Given this list of marker genes FANCC, HTR3C, SUFU, OPRM1 (NCBI Gene Id 4988), ZNF70, CAPZB, NDST1, SMARCD1, TFDP1, PEF1 (penta-EF-hand domain containing 1), TIFAB, STRN4, SDC3, RNF24, NGEF, HGH1, AUTS2, SLC4A5, ESAM, IKZF1, VEGFA, POLR2F, SHISA7, TSLP, MAPKBP1, SEMA5A, KIAA1671, DIXDC1, KCNB1, XPNPEP3, KDM4E, PLXNA1, IL1R1, MYRF, SCAMP5, CDPF1, KCTD7 (potassium channel tetramerization domain containing 7), MITF, NRXN2, RGMA, CNTN2 (NCBI Gene Id 6900), TTC28, TAP2, EEF1AKMT3, PRICKLE1, LINC03040, MRPL19, RAB30 (RAB30, member RAS oncogene family), IFFO2, SELENON, SPOCK2, LBH, COL11A2, PRX, SLC6A6, CERS2, ARHGEF11, EXOC3L2, BCORL1, TTC39C (NCBI Gene Id 125488), TMCC2, CD82, IL17RD, CLDN19, ZDHHC3, FOXM1, MAP2K3, SZRD1, FAM107A, SV2C, ZFR2 (NCBI Gene Id 388494), MEF2D, C5orf24, KCNC4, FAM222B, FADS2, AGO1, BEND4, RBFOX2, RCC2, MARCHF6, RNF121, RAP1GAP2, CRYM (crystallin mu), SLC7A6, NXF1, DHRS2, MEF2A, GLRA4, NCCRP1, SPRR2D, TBC1D20, IDO2, DCC, GRAMD2A, HMGA2, GXYLT1, CREBL2, ZNF747, APBA2, OSBP, CLN8, SLC20A2, FCHSD1, GIPC1, ARHGDIA, HTR4, MTCL2, ZNF185, MAP1A, KIAA0513, COL8A2, BRAP, SH3BGRL3, PAPOLB, INSM2, LRRC27, B3GNT7, MTUS2, FBXO41, CDK2AP2, C19orf84, KRTAP5-2, SPRR2A, KBTBD12, EIF4EBP2, NUTM2G (NUT family member 2G), AIF1L, TRIP6, JRK, FAM20A, PDS5B, DDB1, HAPLN4, CDC42EP4, CDK14, SPRR2E, GLIS3, ABHD2, APPL1, NFAT5, KBTBD13, AEN, NFAM1, ZBTB4, DCAF8, ATP6V0D1, ERCC6L2, LINC02873, EVC, SKI, FLOT2, TOM1L2, ADAM19, G6PC3, FMNL3, RAPGEF1, SPINT3, PRMT5, PIGZ, ADARB1, STN1, SAMD4B, PCYT1A, GPATCH11, NR1D2, PDGFRB, RAB43, SPRR2F, PLXNA2, ARF3, ZNF385A, CDK12, TDO2, CLCN6, MYO18A, DGKH, RAB15, DUSP3, NMUR1, GTF2H3, DIPK2A, GREM1, FOXK1 (forkhead box K1), BBS1, PRSS16, GIT2, FAHD2B, CACFD1, WFDC10B, ARL17A, SYN2, HS3ST2, NYNRIN, ZNRF1, RAB11B, TRIP12, ASF1A, KRTAP5-10, TRIB2, TNPO2, HTR3E, DUSP18, SLC41A1, TBC1D8B, PLA2G2D, VWA5A, SPRR2B, PDE7B, KCNE1, SMG6, C10orf105, KSR2, WNT2B, NPTXR, ZNF444, NPR3, ST8SIA3, WDFY3, P2RY2, TMEM183A, RPH3A, KCNQ2, GFOD2, RUBCN, GNAO1, SATB2, SCUBE3, PDXP, SCN4A, PSMD9, NBL1, MLEC (malectin), TMEM179, KMT2A, CBX2, TET3, ZC3H7B, MS4A18, DDN, SGCZ, CNIH4, BTF3L4, MYO1C, SYT7 (NCBI Gene Id 9066), SORT1, GADD45A, DCLK1, MAPK3, TNNI1, ZNF474, ZKSCAN8, RAPGEFL1, SLC35F6, SYNJ2, CNNM3, ACSL4, TP53I11, NIBAN2, TPP1, CCL22, GNPAT, SNRPD3, SCN3B, RAPGEF3, MRPL15, USP13, RAPH1, ABTB3, ERC1, ZBTB34, SBNO1, SLC6A17, DDX6, B3GLCT, BTBD9, GANC, RAB3B, PPP2R2D, DPT, MYLK4, PRRT2, TMEM138, CSNK1D, ATP1B2, CBX5, ALX4, LTA, ELMO1, ASTN1, ANGPT4, LARP1, MFRP, TCF4, PHKA1, ZDHHC9, here is a description of the gene set: from publication Chen Y, Wang X (PMID 31504780) Human Gene Set: MIR4441 species: Homo sapiens Genes predicted to be targets of miRBase v22 microRNA hsa-miR-4441 in miRDB v6.0 with MirTarget v4 prediction scores > 80 (high confidence targets).